The following is a description of a gene set: A deviation from the normal concentration of osteocalcin in the blood circulation. Human Gene Set: HP_ABNORMAL_CIRCULATING_OSTEOCALCIN_LEVEL studied in species Homo sapiens Abnormal circulating osteocalcin level, and this is the list of marker genes: ANKH, CCDC134, AVP, SLC34A3, FAM20A, ESR1, SLC34A1, FN1, COL2A1